Given this list of marker genes Zc3h4, Pelo, Exosc3, Zcchc7, Supv3l1, Xrn1, Dis3, Exosc10, Exosc2, Trnt1, Exosc6, Exosc4, Wdr82, Exosc7, Exosc5, Exosc9, Dxo, Exosc8, here is a description of the gene set: Mouse Gene Set: GOBP_RNA_SURVEILLANCE studied in species Mus musculus A process that identifies and degrades defective or aberrant RNAs.